The following is a description of a gene set: from publication Chen Y, Wang X (PMID 31504780) Genes predicted to be targets of miRBase v22 microRNA mmu_miR_383_5p in miRDB v6.0 with MirTarget v4 prediction scores > 80 (high confidence targets). species: Mus musculus Mouse Gene Set: MIR_383_5P, and this is the list of marker genes: Adss2, Rbm20 (RNA binding motif protein 20), Akr1c13, Mga, Rnf146, Bloc1s6, Prdx6b, Slitrk4, Rbms1, Lancl1, Rmnd5a, Mapk8, Lrfn5, Nectin3, Gfm2, Pcdh17, Sorcs1, Apod, Ppp1r3c, Mospd2, Mex3c, Anapc5, Zfp282, Tcp11l1, St8sia4, Xk (X-linked Kx blood group), Ppfia2, Arid2, Map7d1, Mal2, Ska1, Ctnnal1, Tent4b, Ap4b1, Cspg5, Celf3, Hs6st3, Tceanc, Neurod1, Srsf2, Prol1, Strn3, Ppp1r2, 1700066M21Rik, Tbck, Akr1c12, Dio1, Nckap1, Man2a1, Fasl (Fas ligand), Gak (NCBI Gene Id 231580), Kynu, Rsf1, Msl2 (NCBI Gene Id 77853), Tmem216, Irf1, Tshr, Slc25a19, Ccdc22, Klhdc10, Fgf6, Npat, Slc2a6, Sla, Htr3a, Elp4